Given this list of marker genes NFATC4, CALM3, PPP3R1, PPP3CB, NFATC3, CALM1, NFATC1, EGF, PLCG2, PPP3CA, PPP3CC, EGFR, NFATC2 (nuclear factor of activated T cells 2), PPP3R2, PLCG1, CALM2, here is a description of the gene set: studied in species Homo sapiens Human Gene Set: KEGG_MEDICUS_REFERENCE_EGF_EGFR_PLCG_CALCINEURIN_SIGNALING_PATHWAY Pathway Definition from KEGG: EGF -> EGFR -> PLCG -> IP3 -> Ca2+ -> CALM == CN -> NFAT EGF-EGFR-PLCG-calcineurin signaling pathway. Pathway ID: N00147. Pathway type: Reference. Pathway class: nt06220 Calcium signaling.